Given this list of marker genes PINK1, RERG, SNW1, DCAF8, CASK, CTCFL, DNMBP, GGA3, ZSWIM5, SOBP, TFB1M, PTCHD3, MITF, JPH3, NCOR1, ATP5F1B, ZBTB47, HSD17B12, AP5B1, KRT82, RHBDD1, SOX10, here is a description of the gene set: Human Gene Set: MIR6789_5P from publication Chen Y, Wang X (PMID 31504780) studied in species Homo sapiens Genes predicted to be targets of miRBase v22 microRNA hsa-miR-6789-5p in miRDB v6.0 with MirTarget v4 prediction scores > 80 (high confidence targets).